Given this list of marker genes HSD17B6, SPR, ADHFE1, AKR1C3, DHRS4L1, RDH8, DHRS4L2, CBR3, KCNAB3, AKR7L, ALDH3A1, RDH13, DHRS2, DHRS4, AKR1D1, MIOX, AKR1B10, RDH5, ADH5, DCXR, RDH12, SDR9C7, DHRS1, ADH4, DHRS7C, ADH1C, AKR7A3, RDH14, KCNAB2, ADH6, ADH1B, DHRS7, HSD17B13, CBR1, SORD, AKR1A1, RDH16, RDH11, DHRS3, AKR1C2, ADH1A, SDR16C5, AKR1C4, RDH10, DHRS9, AKR1B1, AKR1B15, AKR1C1, AKR1E2, KCNAB1, ADH7, AKR7A2, here is a description of the gene set: Catalysis of the reaction: an alcohol + NAD(P)+ = an aldehyde or ketone + NAD(P)H + H+. Human Gene Set: GOMF_ALCOHOL_DEHYDROGENASE_NAD_P_PLUS_ACTIVITY species: Homo sapiens